The following is a description of a gene set: Mouse genes annotated to HALLMARK_INTERFERON_ALPHA_RESPONSE based on orthology mappings provided by the Alliance Genome Consortium from publication Howe DG, Blake JA, Bradford YM, Bult CJ, Calvi BR, Engel SR, Kadin JA, Kaufman TC, Kishore R, Laulederkind SJF, Lewis SE, Moxon SAT, Richardson JE, Smith C (PMID 30224793) studied in species Mus musculus Mouse Gene Set: HALLMARK_INTERFERON_ALPHA_RESPONSE, and this is the list of marker genes: Gbp3, B2m, Slc25a28, Cd74, Nub1, Csf1, Cxcl10, Gmpr, Adar, Sp110, Plscr1, Ifi44, Ncoa7, Trim14, Wars1, Helz2, Psma3, Cmtr1, Elf1, C1s1, Casp1, Uba7, Trim21, Ogfr, Mvb12a, Oasl1, Trim25, Irf2, Lgals3bp, Ifi35, Il15, Sell, Eif2ak2, Ripk2, Lamp3, Ifitm3 (NCBI Gene Id 66141), Cd47, Ifih1, Tdrd7, Txnip, Cnp, Ly6e, Dhx58, Il4ra, Irf1, Tmem140, Oas1a, Psme1, Parp14, Ddx60, Usp18, Procr, Ifit2, Herc6, Psmb8, Ifi44l, Batf2, Mov10, Tap1, Ccrl2, Psmb9, Tent5a, Ifi30, Isg20 (NCBI Gene Id 80487), Ifit3, Psme2, Irf9, Trim26, Pnpt1, Rnf31, Rtp4, Casp8, Ifitm2, Il7, Parp9, Mx2, Nmi, Ube2l6, Ifi27, Lap3, Bst2, Ifitm1 (NCBI Gene Id 68713), Cxcl11, Epsti1, Irf7, Rsad2, Cmpk2, Trim12c, Lpar6 (lysophosphatidic acid receptor 6), Parp12, Samd9l, Isg15, Stat2, Trafd1